Given this list of marker genes KCNJ5, KCNE2, KCNC4, KCNA6, KCNH2, KCNG1, KCNH5, KCNH7, KCNH6, KCNF1, KCNJ13, KCNJ11, KCNJ6, KCNB1, KCNJ16, KCNN3, KCNE5, KCNJ2, HCN4, KCNG3, KCNN1, KCNIP2, KCNS1, HCN3, KCNJ15, ABCC9, KCNH3, LRRC26 (leucine rich repeat containing 26), KCNQ5, KCNA1, KCNG2, KCNJ12, KCNA4, KCNJ9, KCNS3, KCNN2, SCN2B, KCNS2, KCNAB2, KCNC3, KCNK6, KCNC2, KCNMA1, ABCC8, KCNH8, KCNQ3, KCND1, KCNQ2, HCN1, KCNK9, KCNV2, KCNK1, KCNA5, KCNA7, KCNE4, KCNK2, KCNAB3, KCNK12, KCNT1, KCNK5, KCND3, KCNB2, KCNE1, KCNK3 (NCBI Gene Id 3777), KCNQ4, KCNK13, KCNK16, KCNK7, KCNC1, KCNJ4, KCNQ1, KCNA3, KCNH1, KCNA10, KCNA2, KCNJ3, KCNG4, LRRC52, KCNAB1, KCNJ10, KCNK10, KCNJ18, CAV1, KCNK4, HCN2, KCNJ1, KCNK17, KCNJ14, PKD2, KCNH4, KCNT2, SNAP25, KCNK18, LRRC38 (NCBI Gene Id 126755), KCNV1, KCNJ8, LRRC55, KCND2, KCNE3, here is a description of the gene set: Enables the transmembrane transfer of a potassium ion by a voltage-gated channel. A voltage-gated channel is a channel whose open state is dependent on the voltage across the membrane in which it is embedded. species: Homo sapiens Human Gene Set: GOMF_VOLTAGE_GATED_POTASSIUM_CHANNEL_ACTIVITY